The following is a description of a gene set: species: Homo sapiens Human Gene Set: GSE27786_LIN_NEG_VS_CD4_TCELL_DN from publication Konuma T, Nakamura S, Miyagi S, Negishi M, Chiba T, Oguro H, Yuan J, Mochizuki-Kashio M, Ichikawa H, Miyoshi H, Vidal M, Iwama A (PMID 21540074) Each fraction of mouse hematopoietic cells was purified by cell sorting from bone marrow of 8-week-old C57BL/6 mice, and its gene expression was analyzed. Genes down-regulated in comparison of lineage negative versus CD4 T cells., and this is the list of marker genes: PPP2R5E, CLCN5, OSTM1, AKR1B1, CEPT1, NSUN4, AZI2, WASHC2A, LYST, SF3B2, RANBP9, NT5DC1, NDUFA1, MED28 (NCBI Gene Id 80306), TIMP2, ABCG1, GSKIP, TIAM1, NEMF, NCMAP, RTP4, TSKS, EPB41L2, ARMC3 (armadillo repeat containing 3), SMAD4, ZMAT2, RRP36, STX4, TAFA3, MAP3K1, HERC2, SOCS3, PTPRCAP, TSSK4, LSM4, HERPUD2, EBP, ZNF646, NLRC5, NRDC, HIGD2A, JAK1, PSME1, SELENOP, RSF1, PRSS55, CFLAR, PIK3IP1, PLAAT3, TBL1XR1, ANAPC16, CHMP1A, SORL1, ATP8A2, GLRX, DDRGK1, MSS51, UBXN4, GREM2, PHF1, MTMR3, NFATC2, LY9 (lymphocyte antigen 9), ARPC5L, ANO10, MED12, RPS26, TGFB3, ZBTB20, PPP2R2A, ITGAL, NCKAP1L, ALDOC, FOXN3, TRIM5, HUWE1, RGS14, CCDC88B, TRNAU1AP, PREX1, PRXL2C, IER5, SUPT20H, ZMIZ2, GIT2, RIT1, CHIC2, LIME1, PRDM2, OTUD7B, KCNC4, SLC39A14, SPO11, KIDINS220, FBXO25, CLK4, GALNT4, TNFAIP1, KCNAB2, EFR3A, RRAD, SLC20A1, SDR39U1, ANTKMT, NSD3, SQSTM1, DOK2, RPS19, YAF2, DZIP1, ASB3, POLR3C, PCMTD1, PPP1R35, ARID5A, CACTIN (NCBI Gene Id 58536), ANKIB1, AXIN1, LGALS1, PPM1B, ZBTB2, IL21R, COA4, HADHB, EZH1, IDH3B (isocitrate dehydrogenase (NAD(+)) 3 non-catalytic subunit beta), CYSLTR2, PPEF2, HMOX2, MTFMT, UBR1, EML3, ATOSA, ATF2 (activating transcription factor 2, NCBI Gene Id 1386), ZNF707, TMA7, BAHD1, C19orf12, PMEPA1, DGAT2, TRAPPC8, ALG5, TBX6, BORCS6, RAB24, IFITM10, EIF1B, MAP2K7, UPF3A, MBD2, NKIRAS1, APOBEC2, IRF7, SLC25A2, KRT78, HSD17B11, NOL7, TAP1, PPP1R12C, LPXN, GGNBP2, ID2, GABRR2 (NCBI Gene Id 2570), NMI, CHD7, CNDP2, PRSS8, DEGS1, SMAD2, GPR171 (NCBI Gene Id 29909), KMT2A, SCG5, IKZF1, TET2, PTPN23, F2RL1, AFP, TOMM7, LPGAT1 (NCBI Gene Id 9926), CTSO, RALGAPB, POGZ, MARK2, TMEM179B, MYO1E, PPCDC, TNFRSF1B, B4GALNT2, CYP2D6, ANKRD11, SLC30A1, MED13L, ARHGEF4, IL2RB, BRD9, CHCHD2, ARL6IP1, FHIP1A, SEC24B, PAFAH1B1